The following is a description of a gene set: Human Gene Set: HP_RESPIRATORY_INSUFFICIENCY_DUE_TO_DEFECTIVE_CILIARY_CLEARANCE Respiratory insufficiency due to defective ciliary clearance species: Homo sapiens, and this is the list of marker genes: SPAG1 (NCBI Gene Id 6674), DNAAF11, CFAP298, HYDIN, ODAD1 (NCBI Gene Id 93233), ODAD3, ZMYND10, CCDC65, ODAD2, DNAAF5